The following is a description of a gene set: part of: Metabolism of proteins Reactome Pathway: Peptide hormone metabolism Peptide hormones are cleaved from larger precursors in the secretory system (endoplasmic reticulum, Golgi apparatus, secretory granules) of the cell. After secretion peptide hormones are modified and degraded by extracellular proteases.<br>Insulin processing occurs in 4 steps: formation of intramolecular disulfide bonds, formation of proinsulin-zinc-calcium complexes, proteolytic cleavage of proinsulin by PCSK1 (PC1/3) and PCSK2 to yield insulin, translocation of the granules across the cytosol to the plasma membrane.<br>During Synthesis, secretion, and deacetylation of Ghrelin, proghrelin is acylated by ghrelin O-acyltransferase and cleaved by PCSK1 to yield the mature acyl ghrelin and C-ghrelin. In the bloodstream acyl ghrelin is deacylated by butyrylcholinesterase and platelet-activating factor acetylhydrolase.<br>During Metabolism of Angiotensinogen to Angiotensin, Renin cleaves angiotensinogen to yield a decapaptide, angiotensin I (angiotensin-1, angiotensin-(1-10)). Two C-terminal amino acid residues of angiotensin I are then removed by angiotensin-converting enzyme (ACE), located on the surface of endothelial cells, to yield angiotensin II (angiotensin-2, angiotensin-(1-8)), the active peptide that causes vasoconstriction, resorption of sodium and chloride, excretion of potassium, water retention, and aldosterone secretion. More recently other, more tissue-localized pathways leading to angiotensin II and alternative derivatives of angiotensinogen have been identified and described.<br>Incretin synthesis, secretion, and inactivation occurs through processing of incretin precursors (preproGLP-1 and preproGIP) by PCSK1. After secretion both incretins (GLP-1 and GIP) can be inactivated by cleavage by DPP4.<br>Peptide hormone biosynthesis describes processing of glycoprotein hormones (those which include carbohydrate side-chains) and corticotropin. studied in species Homo sapiens, and this is the list of marker genes: RAB27A, KIF5A, REN, CPA3, IGF1, SPCS1, GNAT3, GATA4 (GATA binding protein 4), EXOC7, SPCS2, BCHE, CGA, CTNNB1, DPP4, SLC30A5, POMC, ANPEP (alanyl aminopeptidase, membrane), MYRIP, KLF4, EXOC4, INS, CTSZ, CES1, SLC30A8, FFAR4 (NCBI Gene Id 353126), UCN, GZMH, P4HB, AGT, GNB1, ERO1B, ACHE, ISL1, CPE, SPCS3 (signal peptidase complex subunit 3), EXOC2, ENPEP, MBOAT4 (membrane bound O-acyltransferase domain containing 4), INHBA, EXOC1, EXOC3, CLTRN, CTSG, KIF5B, STX1A, GRP, TSHB, LHB, GNG13, GH1, EXOC6, GPR119, FFAR1, EXOC8 (exocyst complex component 8), CPB1, MME, PCSK1, LEP, GNB3, INHA, PAX6, ATP6AP2, MYO5A, CRHR2, CMA1, INHBE, FSHB, PCSK2, CGB3, CTSD, ACE2 (angiotensin converting enzyme 2), VAMP2, INHBB, INHBC, KIF5C, SEC11A, CPB2, GIP, TCF7L2, SEC11C, EXOC5, ACE, PLA2G7, GHRL, CDX2, GCG